The following is a description of a gene set: The formation of a protein heterotetramer, a macromolecular structure consisting of four noncovalently associated subunits, of which not all are identical. Human Gene Set: GOBP_PROTEIN_HETEROTETRAMERIZATION species: Homo sapiens, and this is the list of marker genes: NUDT21 (NCBI Gene Id 11051), CBR4, KRT1, HSD17B8, GRIN2B, PKD2, PKD1, CPSF6 (NCBI Gene Id 11052), KRT10 (keratin 10), FARSB, FARSA, GRIN1, CPSF7, RRM2, RRM1, GRIA3